The following is a description of a gene set: Signal regulatory protein family interactions Human Gene Set: REACTOME_SIGNAL_REGULATORY_PROTEIN_FAMILY_INTERACTIONS studied in species Homo sapiens, and this is the list of marker genes: TYROBP, SIRPB1, PTK2, SIRPG, CD47, SFTPA1, SKAP2, PTPN6, SFTPA2, FYB1, SIRPA, PTK2B, SRC, GRB2, PTPN11, SFTPD